The following is a description of a gene set: species: Homo sapiens Human Gene Set: REACTOME_SUMOYLATION_OF_TRANSCRIPTION_COFACTORS SUMOylation of transcription cofactors, and this is the list of marker genes: CBX2, RING1 (NCBI Gene Id 6015), HIPK2, DDX17, SUMO3, UBE2I, SAFB, SUMO1, PIAS3, PCGF2, TRIM28, CBX8, SIN3A, PIAS2, PIAS4 (protein inhibitor of activated STAT 4), ZNF131, DAXX, PHC3, CBX4, CREBBP, PARK7, NCOA2, EP300, TOPORS, RNF2, NRIP1, SUMO2, PHC1, CASP8AP2, ZNF350, NCOA1, MBD1, PIAS1, NPM1, NCOR2, DDX5, PHC2, PPARGC1A, BMI1, UHRF2, ING2, CTBP1, MRTFA, SCMH1